Given this list of marker genes Psmb6, Psmb5 (proteasome (prosome, macropain) subunit, beta type 5), Psmc4, Tgfb1, Psmd12, Psmd6, Psmc5, Psmb4, Smurf1, Smurf2, Psma3, Psmb7, Psmd1, Psma2, Rps27a, Psmc3, Psma7, Psma6, Psma4, Psma1, Ep300, Psmc1, Psmd13, Psmc6, Psmc2, Psma5, Cbfb, Psmd7, Ubb, here is a description of the gene set: This event has been computationally inferred from an event that has been demonstrated in another species.<p>The inference is based on the homology mapping from PANTHER. Briefly, reactions for which all involved PhysicalEntities (in input, output and catalyst) have a mapped orthologue/paralogue (for complexes at least 75% of components must have a mapping) are inferred to the other species. part of: Transcriptional regulation by RUNX3 species: Mus musculus Reactome Pathway: Regulation of RUNX3 expression and activity electronically inferred by orthology from the curated human pathway